Given this list of marker genes Rara, Nr2f1, Rxra, Rxrg, Myt1l, Rxrb, Zfp536, here is a description of the gene set: Mouse Gene Set: GOMF_RETINOIC_ACID_RESPONSIVE_ELEMENT_BINDING Binding to a retinoic acid-responsive element, a variable direct repeat of the sequence PuGGTCA spaced by five nucleotides (DR5) found in the promoters of retinoic acid-responsive genes, to which retinoic acid receptors bind. species: Mus musculus